Given this list of marker genes CHRNA7, SEC14L2, SPATA31F3, ESM1, SHF, P3H1, USP46, SYPL2, ADAMTS19, NXPH1, TRNP1, AS3MT, ZBTB16, DUSP13B, ACYP1, GPR157, PHETA1, PATL2, SSPN, ERICH5, MIR326, NAT8B, FAM24A, TPPP3, ANKS4B, IHH, ELFN2, ARL4C, PTGES2, DIP2A (NCBI Gene Id 23181), SCNN1B, TRAPPC14, PIM3, AVIL, FAM184A, HNF4A, SRL, LHFPL7, KCNJ2 (potassium inwardly rectifying channel subfamily J member 2), KLHL36, SIGLEC15, KRTAP1-5, BCO2 (beta-carotene oxygenase 2), CNIH2, HGF, CTNNA3, SLC22A23, GPX8, SEMA3C, KCNJ8, SPR, NTSR2, RGS11, NKX2-1, CX3CR1, HHATL, PVALB (NCBI Gene Id 5816), TCP11, CHAT, TIGD3, DDX23, TNFAIP8L3, SPN, EDNRA, TMEM237, DHODH, SLC41A3, CD247, PPP1R3E, USH2A, TMEM37, L1TD1, NPAS2, COL8A2, FCGRT, FOXH1, MEIS3, KCNA7, TSKS, LCE1D, INHBB, CFI (NCBI Gene Id 3426), PLCH2, HECTD2, GARIN1B, EGF (NCBI Gene Id 1950), RFNG, PREX2, PLG, HCRTR1, MAP3K6, PTTG1IP, LAMA4, ABHD12B, JPH3, CBY3, LOXHD1, HRH1, GSC2, ERFE, CARD6, DISP2, HTR1F, SBNO2, FAM3A, SULT4A1, SDK2, TRPM2, SORCS2, NUP210L, RABEP2, VPREB1, CREBL2, CLDN11, URM1, PROX2, PCDHB6 (NCBI Gene Id 56130), GASK1A, KRTAP5-1 (NCBI Gene Id 387264), RRP9, MGAM, CGREF1, GZMA, CACNA1G, SLC25A5, FAM117A (family with sequence similarity 117 member A), ZEB2, PAX3, S1PR5, FAM47A, TCF3, EVL, TMPRSS9, NKX2-5, ADCYAP1, PCYOX1L, ADAM28, POU3F3, JAK1 (NCBI Gene Id 3716), ANKRD34A, NAGS, HEXD, PDGFB, here is a description of the gene set: studied in species Homo sapiens from publication Zhang X, Jin J, Tang Y, Speer D, Sujkowska D, Markovic-Plese S (PMID 19265172) Genes up-regulated in peripheral blood mononclear cells (PBMC) from multiple sclerosis (MS) patient: untreated versus IFNB1. Human Gene Set: GSE14386_UNTREATED_VS_IFNA_TREATED_ACT_PBMC_MS_PATIENT_UP IFNβ, an effective therapy against relapsing-remitting (RR) multiple sclerosis (MS) is naturally secreted during the innate immune response against viral pathogens. The objective of this study was to characterize the immunomodulatory mechanisms of IFNβ targeting innate immune response and their effects on DC-mediated regulation of T-cell differentiation. We found that IFNβ−1a in-vitro treatment of human monocyte-derived dendritic cells (DCs) induced the expression of TLR7 and the members of its downstream signaling pathway, including myeloid differentiation factor 88 (MyD88), IL-1R-associated kinase (IRAK)4, and TNF receptor-associated factor (TRAF)6, while it inhibited the expression of IL-1R. Using siRNA TLR7 gene silencing, we confirmed that IFNβ-1a-induced changes in MyD88, IRAK4 and IL-1R expression were dependent on TLR7. TLR7 expression was also necessary for the IFNβ-1a-induced inhibition of IL-1β and IL-23, and the induction of IL-27 secretion by DCs. Supernatant (SN) transfer experiments confirmed that IFNβ-1a-induced changes in DCs’ cytokine secretion inhibit Th17 cell differentiation as evidenced by the inhibition of retinoic acid-related orphan nuclear hormone receptor C (RORC) and IL-17A gene expression and IL-17A secretion. Our study has identified a novel therapeutic mechanism of IFNβ−1a, that selectively targets the autoimmune response in MS.